The following is a description of a gene set: This event has been computationally inferred from an event that has been demonstrated in another species.<p>The inference is based on the homology mapping from PANTHER. Briefly, reactions for which all involved PhysicalEntities (in input, output and catalyst) have a mapped orthologue/paralogue (for complexes at least 75% of components must have a mapping) are inferred to the other species. part of: Deubiquitination studied in species Mus musculus Reactome Pathway: Ub-specific processing proteases electronically inferred by orthology from the curated human pathway, and this is the list of marker genes: Usp12, Smad3, Nfkbia, Myc, Wdr48, Smad7, Axin1, Usp25, Psmc3, Psmc5, H2ac10, H2ac1, Rps27a, Hif1a, Usp21, Psma5, H2ac13 (H2A clustered histone 13), Psma2, Psma7, Rnf146, Smad1, H2ac6, Axin2, Fkbp8, H2ac19, Psmd12, Birc3, Vdac1, Psmd1, Trp53, Taf10, Tomm20, Otub1, Usp19, Gata3, Usp17ld, Usp26, Usp47, Ccna1, Psmc4, Psmd7, Ufd1, H2ac11, Mul1, Vdac2, Rigi, Ifih1, Usp5, H2ac12, Psmc6, Usp17lb (NCBI Gene Id 381944), Psma4, Tnks2, H2ac25, Usp28, Ubb, Taf9b, Usp17la, H2ac24, Ptrh2, Wdr20, Usp22, Usp42, H2ac22, Psmb5, Il33, Becn1 (NCBI Gene Id 56208), Usp29, Usp17lc, Psmc1, Psma1, H2ac23, H2ac15, Psmb7, Usp37, Usp4, Smurf2, H2ac20, Snx3, Rnf128, Psma6, Cyld, H2ac8, Psmd13, Rnf123, Psmc2, Psmd6, Ar, H2ac4, Psma3, H2ac7, Foxo4, Arrb2 (NCBI Gene Id 216869), Tab1, Suds3, Psmb4, Vdac3, Usp3, Usp44, Psmb6